Given this list of marker genes Hdac1 (NCBI Gene Id 630524), Esr2, Igf1, Ncor2, Smarca4, Phb1, Nodal, Sirt1, Tcf21, Pias2, Dab2, Zbtb7a, Heyl (NCBI Gene Id 56198), Foxh1, Pten, Sfrp1, Foxp1 (NCBI Gene Id 73231), Ncor1, here is a description of the gene set: studied in species Mus musculus Mouse Gene Set: GOBP_NEGATIVE_REGULATION_OF_ANDROGEN_RECEPTOR_SIGNALING_PATHWAY Any process that decreases the rate, frequency, or extent of the androgen receptor signaling pathway.